Given this list of marker genes RIC8A, ACER2, ARF1, BSCL2, CIZ1, SMIM3, WWC3, CAPN2, TSPAN13, ORAI2, UXS1, TBC1D22A, TMCO3, MYL6, PLA2G4C, CA7, BSDC1, GPAT4, CCNY, LAMC1 (laminin subunit gamma 1), VKORC1, PGAM1, C20orf96, HLA-J, KHK, STIMATE, SPOCD1, RHOC, LINC00963, FTH1P2 (NCBI Gene Id 440727), MLLT11, BLTP3A, ARHGDIB, PTMAP9, FTH1P10, ARPC1B, UBE2Z, TRPC2, GALM, ASS1P1, ILRUN, PGD, CCDC88C, AP2M1, TBC1D20, GIPC3, FTH1P11, HINFP, TPI1P1, GRK4, HSPA2, DISP1, KCTD2, EIF2AK1, ZHX1-C8orf76, TMT1A, NINJ1, FTLP2, ATF4P4, C1orf198, H3C3, ANXA11, PACSIN2, IGF2BP2, SFXN5, UBE4B, KIF3C, P2RX1, MEMO1P1, MAP1A, MGST2, G6PD, PLIN3, SMIM10L1, F11R, HDAC2-AS2, DAG1, GUSB, SVIL, SLC22A17, ARID1A, SPARC, AP1B1, SUGT1P1, FURIN, SNRPN, ST3GAL1, CDYL2 (chromodomain Y like 2), TAX1BP3, SNHG30, FTH1P20, VNN1, ING4, AP2B1, TMEM11, MED16, MYLK, FAM229A (NCBI Gene Id 100128071), PAQR7, ENTREP3, BAP1, TBC1D13, RPL41, IMPA2, GSN, MECP2, WDR1, SPSB4, CAPN1, ARHGEF12, JTB, HLA-G, CALCOCO1, RTN1, TPST2, TMEM164, PIGS, RAB13, POMGNT2, SEC14L2, WDR13, ATF4, ATXN7L3, SMPD1, NUTF2, FTH1P12, LINC02284, GABRD, C2orf68, ZNF460-AS1, WASF1, MYL6P5, PRKCA, SH3BP4, MINDY1, DNAJB2, NAP1L4, FUNDC2, FTL, KLHDC8B, ZBTB4, FUNDC2P1, STIM1, STK40, CUX1, BCR, SLC3A2, ERCC1, RNF24, NCKIPSD, ABHD17A, PTMAP10, FTH1P7, MYO18B, USP39, FTLP3, TRAPPC5, ITGB5, UBE3B, PI4KA, CCDC9B, MCEMP1, PCSK6 (proprotein convertase subtilisin/kexin type 6), CDC37, MAPKAPK2, CTSA, here is a description of the gene set: Genes up-regulated in patients with a hyperreactive platelet phenotype Human Gene Set: BERGER_PLATELET_HYPERREACTIVITY_PRESS_UP from publication Berger JS, Cornwell MG, Xia Y, Muller MA, Smilowitz NR, Newman JD, Schlamp F, Rockman CB, Ruggles KV, Voora D, Hochman JS, Barrett TJ (PMID 39164233) Platelets are key mediators of atherothrombosis, yet, limited tools exist to identify individuals with a hyperreactive platelet phenotype. In this study, we introduce a tool, the Platelet Reactivity ExpreSsion Score (PRESS), which integrates platelet aggregation responses and RNA sequencing. PRESS performs well in identifying a hyperreactive phenotype in patients with PAD (AUC 0.81, 95% CI 0.68 -0.94, n = 84) and in an independent cohort of healthy participants (AUC 0.77, 95% CI 0.75 -0.79, n = 35). Following multivariable adjustment, PAD individuals with a PRESS score above the median are at higher risk for a future cardiovascular event (adjusted HR 1.90, CI 1.07–3.36; p = 0.027, n = 129). Incorporating PRESS into the analytical pipeline, PRESS was enriched in the platelet transcriptome of patients with versus without atherosclerosis. In conclusion, this study derives and validates the ability of PRESS to discriminate platelet hyperreactivity and identify those at increased cardiovascular risk. studied in species Homo sapiens